The following is a description of a gene set: from publication Chen Y, Wang X (PMID 31504780) Human Gene Set: MIR96_5P studied in species Homo sapiens Genes predicted to be targets of miRBase v22 microRNA hsa-miR-96-5p in miRDB v6.0 with MirTarget v4 prediction scores > 80 (high confidence targets)., and this is the list of marker genes: GRHL2, NCALD, REPS2, NRN1, RASA1 (NCBI Gene Id 5921), KIAA0513, EIF5, SLITRK4, THBS2, TBR1, CERS2, BRINP2, ADGRB3, SLC1A1, MTCL2, PLAAT5, ADGRL2, SEZ6L, FKBP7, ITPR2, DHX8, ITPR1, SDC2 (NCBI Gene Id 6383), GBP5, SERPINB2, NANOS1, STK19, YES1, HBP1, TMEM198, ATP2B4, KCNG3, CBFA2T3, RAB10, PALLD, OVOL1, CTTN, PHIP, FBXO41, SCYL3, PPP3R1, SLC9A2, TMEM170B, PHAF1, SPRY3, SLC18A3, BNC2, BCL2L12, LGI1, VAT1, PPP1R11, SPAG8, PTGER3, SAR1B, MAP2K1 (mitogen-activated protein kinase kinase 1), MTOR, ARPC5L (NCBI Gene Id 81873), EXT1, PRKCE, KRAS, DLEU7, TARBP1, RGPD1, RARG, NUS1 (NUS1 dehydrodolichyl diphosphate synthase subunit), QKI, NUDT13, PNPLA1, TOPORS, PLAGL1, NEXMIF, CREBRF, NEUROD4, UBE2G1, CHIC1, PLOD2, FAM216A, ZNF850, CASP2, PYGO2, CTDSP1, SLC7A8 (solute carrier family 7 member 8), UNC13C, HBEGF, RNF139, RAB35, PC, MAP2K3, COL13A1, LNX2, ABHD13, SINHCAF, CNNM3, RGS17, FNDC3B, CD164, RAB8B, CADM2, CEP170B, AJAP1, SLC16A9, TNS3, SPAST, COL25A1, ZBTB41 (NCBI Gene Id 360023), SHC4, MIGA1, REV1, ZNF667, TMEM169, ZCCHC3, L1CAM, GPR135 (G protein-coupled receptor 135), GNAO1, PRRT3 (proline rich transmembrane protein 3), PDZRN4, DNAAF9, NDST1, SERINC5, SMAD1, MCMBP, CACNA2D2, RDH11, PPM1F, PLPPR4, STK17B, CRKL, RFTN1, AHR, DDHD1, AATK, VAMP3, USF3, RITA1, RAB23, SNX16, SLC39A9, DENND2C, HDAC7, MED14 (mediator complex subunit 14), BICD2, TAPT1, DHCR24 (NCBI Gene Id 9800), CYRIB, FRS2, PTP4A1, SNX30, NPTX2, CAMKK2, KCTD2, DOCK4, STAG1, STX5 (syntaxin 5), RAD23B, RAB2A, SLC33A1 (NCBI Gene Id 9197), GPHN, DPYD, EPHA3, ST7, KIAA1217, MAP3K3, CLN5, CNN3, LPP, AZIN1, PBX2, B3GNT2, RICTOR, FOXO3, DAAM1, OXGR1, ANXA11, GCNT1, PPP3CA (protein phosphatase 3 catalytic subunit alpha), LRRC3, FN1, SORT1, ATXN1, CHST1, MRAS, SH3BP5, XKR4, DOCK1 (dedicator of cytokinesis 1), IGSF11, RHPN2, OXSR1, LRRC7, MAP3K2, OTUD6B, LILRA1, TTYH3, FOXK2, POU2F2, FOXQ1, ACTRT3, TCF7L2, DDAH1, PAFAH1B1, AQP2, BRWD3, ARPP19, RASSF8, INSIG2, PCCA, PRRX1, IGF2BP1, PCGF5, GABRB1, MTDH, PTPMT1, JPT2, SLC35A1, RAB3C, TRIO, FGF9, CPEB1 (NCBI Gene Id 64506), RALGPS1, PPIL1, USP5, FZD3, SPIN1, PHYHIPL, RIOX1, MAGEL2, LDB3, RWDD4, NOVA2, CRYGS, B4GALNT1, PRIMA1, MROH2A, ZFAND5, PIK3C2A, SOX5, ZHX1, PAIP1, PPM1L, CNOT6L, STK17A, PLCB4, C5orf22, MYRIP, BRMS1L (BRMS1 like transcriptional repressor), ZEB1, HSPA2, MORF4L2, NOVA1, SPSB1, DEUP1, RNF183, EVI5, RAPGEF4, CHST10, MITF, GXYLT1, SLC12A5, RGS2, SLC26A9, GJC1, CLVS2, FBXW11, ST6GALNAC3, HAS2 (NCBI Gene Id 3037), SIN3B, DOCK9, CAMK2N1, E2F5, EDEM1 (ER degradation enhancing alpha-mannosidase like protein 1), PHF20L1, ABCD1, GAN (NCBI Gene Id 8139), DLAT, ADD3, BCR, LRRC4, ZNF704, PURA, KLHL7, PPP4R3A, GDNF, ATG9A, ELOVL5, SLC6A9, SLC22A5, PSME4, NLGN2, CACNB4, LAMC1, ADCY6, FARP1, TMEM52B, LRIG1, PDE8B, PDZD8, ARHGEF3 (NCBI Gene Id 50650), SELENOI, SLC38A4, TAF4B, ERC2, OLFM1, STMND1, ATXN3, CREB3L2, PEDS1, EIF3J, MFAP3L, FOXF2, PAK1, SLC39A1, ARHGAP6, ADGRA2, CNTN1, PIK3R1, NHLRC3, RPS6KA6, FEM1B (NCBI Gene Id 23374), MAP1B, ANKIB1, PHACTR4, ZFP36L1, SLF2, GNAI3, DMXL1, GIT2, KCNK9, MAST4, KCNJ14, LCP1, RUNDC3B, ADK, RBM20, SPEN, SLC12A6, MSN, ERLIN1 (ER lipid raft associated 1), ZFHX4, TRIM46, NEK7, LRCH2, PLEKHM1, ALK, NCKAP1, TUT4, WIPI2, MAPRE1, SH3KBP1, OR10W1, YWHAG, MORF4L1, SOX6, SH3PXD2B, DCUN1D1, HOOK3, FAM171A1, EIF4EBP2, MTHFD2L, ELAVL4, GAP43, LMTK2, EDNRB, KPNB1, SIK3, MFAP3, LMTK3, DEPDC1, MAK, FAM43A, TPR, KLHL34, RAB27A, TBL1X, PPP1R9B, IRS1, AEBP2, ARHGEF12, ZDHHC17, ABCA2, ERG, VAT1L, OGT, MTSS1, SV2C, CDH20, SEPTIN9, SLC44A2, CELSR1, SESN3, FRMD5, TRABD2B, PRKAR1A, RELL1, DEPTOR, EPAS1, YIPF4, CELSR2, TAC1, LHX1, C2orf72, PGAP1, IGF1R, APPL1, DPY19L3, NTN4, WDR82, PRDM16, GALNT2, FOXO1, ZFC3H1, ZIC2, AP3S1, TRIM9, TOX, BRPF3, USP45, EBF3, GLE1, DCUN1D3, CDK18, BNIP3, CPSF6, SLC44A5, CAV1, KLHL4, GPC3, ANKRD27, HOXA9, AK3, TRIB3, EOMES, FYCO1, GRIA1, ZHX2, PRTG, UCK2, PPP4R2, SLAIN2, REEP1, AGO4 (NCBI Gene Id 54791), LRRC28, MED1, ASH1L, PRRG3, ATG16L1, GPR22, SLC24A4, BICRAL, GRB2, ZCCHC14, SCML4, RALB, JMJD1C, UBE2Q2, CLOCK